Given this list of marker genes HMMR, LTN1, MARCKS, FXR1, B2M, BAG6, ESRP1, RNF43, MAP1S, MSH3, CTNND1, PHF14, NCOR1, here is a description of the gene set: Human Gene Set: IVANOV_MUTATED_IN_COLON_CANCER studied in species Homo sapiens Inhibition of the nonsense-mediated decay (NMD) mechanism in cells results in stabilization of transcripts carrying premature translation termination codons. A strategy referred to as gene identification by NMD inhibition (GINI) has been proposed to identify genes carrying nonsense mutations. Genes containing frameshift mutations in colon cancer cell line have been identified using a modified version of GINI. To increase the efficiency of identifying mutant genes using GINI, we have now further improved the strategy. In this approach, inhibition of NMD with emetine is complemented with inhibiting NMD by blocking the phosphorylation of the hUpf1 protein with caffeine. In addition, to enhance the GINI strategy, comparing mRNA level alterations produced by inhibiting transcription alone or inhibiting transcription together with NMD following caffeine pretreatment were used for the efficient identification of false positives produced as a result of stress response to NMD inhibition. To demonstrate the improved efficiency of this approach, we analysed colon cancer cell lines showing microsatellite instability. Bi-allelic inactivating mutations were found in the FXR1, SEC31L1, NCOR1, BAT3, PHF14, ZNF294, C19ORF5 genes as well as genes coding for proteins with yet unknown functions. from publication Ivanov I, Lo KC, Hawthorn L, Cowell JK, Ionov Y (PMID 17086209) Genes mutated in colon cancer cell lines, identified using the GINI method described in the paper.